Given this list of marker genes Cyp3a11, Cyp2c66, Cyp3a59, Alox12, Cyp2e1, Ltc4s, Cyp3a25, Cyp1a1, Ephx2, Lta4h, Alox15, Alox5, Alox5ap, Gpx4, Cyp3a13, Cyp3a44, Cyp2c65, Hpgd, Cyp3a41b, Cyp3a16, Cyp3a41a, Cyp1a2, Ptgs2, Cyp2d22, Cyp3a57, Gstm4, here is a description of the gene set: Mouse Gene Set: REACTOME_BIOSYNTHESIS_OF_SPECIALIZED_PRORESOLVING_MEDIATORS_SPMS Biosynthesis of specialized proresolving mediators (SPMs) studied in species Mus musculus